The following is a description of a gene set: Severe cytomegalovirus infection species: Homo sapiens An unusually severe infection by cytomegalovirus. Human Gene Set: HP_SEVERE_CYTOMEGALOVIRUS_INFECTION, and this is the list of marker genes: PTEN, MAGT1, MCM10, REL, PIK3CD, CD28, CARD11 (NCBI Gene Id 84433), RFXANK, IL2RB, DEF6, PIK3R1, IKBKG, LAT, TPP2